Given this list of marker genes Bnip2, Smg6, Tmem164, Tpm4, Cep120, Tnr, Fgf14, Tspan9, Slc25a53, Zfand5, Nfasc, Tmem47, Tubgcp4, Zmynd11, Mtss1 (NCBI Gene Id 70087), Ccr2, Caln1, Zfp422, Rnf114 (ring finger protein 114), Cacng2, Kmo, Fgf7, Map3k13, Cd300ld, Kctd9, Ano1, Urm1, Noxo1, Usp9x, Pcdh17, Snrk, Hsd3b7, Gcnt2, Kcnb1, Nkx3-1, Zbtb39, Glcci1, Desi2, Slc7a4, Tra2b, Ppm1f, Zfp148, Mier3, Ensa, Ncdn, Dusp9, Btaf1, Stk40, Myog, Brwd3, E2f2 (NCBI Gene Id 329958), Col19a1, Neurl1a, Abr, Usp5, Efna5, Cntnap1, Phf21a, Jun, Unk, Ttll4, Casq2, Kit, Diaph1, Lin28b, Smap2, Lclat1, Elovl5, Rhobtb1, Serbp1, Kdm2a, Erbb2, Prpf38a, Zbtb4, here is a description of the gene set: from publication Chen Y, Wang X (PMID 31504780) Genes predicted to be targets of miRBase v22 microRNA mmu_miR_7017_3p in miRDB v6.0 with MirTarget v4 prediction scores > 80 (high confidence targets). Mouse Gene Set: MIR_7017_3P studied in species Mus musculus